The following is a description of a gene set: studied in species Mus musculus Mouse Gene Set: GOCC_PEPTIDASE_COMPLEX A protein complex which is capable of peptidase activity., and this is the list of marker genes: Sf3b5, Immp1l, Supt3, Sgf29, Ide, Plaur, Pmpcb, Psmb2, Slc10a2, Psmd11, Cfh, Taf5l, Gpaa1, Spcs3, Zfand2b, Tada2b, Psma2, Psme1, Trrap, Kat2b, Elp2, Arxes2, Pigu, Taf12, Taf6, Fap, Taf10, Psmd2, Capns1, Capn1, Psme4, Psmd3, Psmd5, Psmd1, Tada3, Txnl1, Pigk, Psma8, Psmb10, Usp25, Kat2a, Psmc4, Tada1, Capn2, Psmb6 (proteasome (prosome, macropain) subunit, beta type 6), Psme2, Rad23b, Psmd6, Mbl2, F3, Atxn7l3, Taf9, Ecpas, Arxes1, Ubqln4, Psmd4, Adrm1, Casp9, Psma1, Ubqln1, Thbd, Psmc2, Psma7, Psmd7, Psmb11, Psmb5, Htra2, Supt7l, Adrm1b, Psma6, Fcnb, Psmc6, Psmd13, Psmd8, Psmd14, Psmb4, Psma4, Rad23a, Eny2, Cfhr4, Cradd (NCBI Gene Id 12905), Prickle1, Pigs, Sec11a, Capns2, Psmb3, Hspb1, Psmc1, Spg7, Ube3a, Psmb7, Psmb1, Afg3l1, Psmc5, Psmd9, Ubr1, Taf5, Pidd1, Atxn7, Psma5, Psmd10, Psmd12, Casp2, Psmb9, Dnajb2, Usp14, Sec11c, Pigt, Spcs1, Psma3, Psme3, Taf6l, Sem1, Sf3b3, Psmc3, Psmb8, Spcs2, Tada2a, Psmf1, Plau, Supt20, Uchl5, Usp22, Zfand2a, F7, Immp2l, Vcp, Afg3l2